Given this list of marker genes PAN3, KRT23, IL17D, TXNIP, TRMT1L, RFX5, DPP4, UGT2A3, KHDRBS2, MAP3K2, PTPDC1, BAG5, ZNF550, ZNF814, EMC2, PDHA2, RBM8A, VGLL2, PGM3, EFEMP1 (NCBI Gene Id 399564), RELL1, CA12, ATF7, KRTAP7-1, CD40LG, MTFR1L, FMO2, SLC1A1, VKORC1L1, MTMR4, CDK2AP1 (cyclin dependent kinase 2 associated protein 1), SGIP1, IRAG1, CHMP5, NAIP, SCGB2B2, FCMR, YWHAB, LRRN2, CELF3, ANGEL2, UBAP1, FRAS1, SORBS1, TNFSF8, GDPD5, HTR2C, SLITRK5, GHR, KMT2A, EML4, PPM1D, C2orf72, TNRC6B (trinucleotide repeat containing adaptor 6B), RC3H1, WNT3, INTS4, SRL, LRPAP1, NUDT4, PSMD14, here is a description of the gene set: Human Gene Set: MIR873_3P from publication Chen Y, Wang X (PMID 31504780) Genes predicted to be targets of miRBase v22 microRNA hsa-miR-873-3p in miRDB v6.0 with MirTarget v4 prediction scores > 80 (high confidence targets). studied in species Homo sapiens